Given this list of marker genes MYD88, NPC1, MIR146A, SYK, FCER1G, CD36, ADTRP (androgen dependent TFPI regulating protein), APOE, MIR4286, TGFB1, FUT1, TICAM1, CD68, LDLR, TLR4, CASR (NCBI Gene Id 846), TREM2 (NCBI Gene Id 54209), ITGB2, TXNIP, CD81, MIR135A1, MIR20A, ITGB1, ABCA1, APP, CES1, TLR6 (toll like receptor 6), MIA3, CDH13, SREBF2, MIR302A, SOCS5, MIR92A1, MIR758, LPL, SMPD3, PPARG, AKT1, CD9 (CD9 molecule), here is a description of the gene set: Human Gene Set: GOBP_RESPONSE_TO_LIPOPROTEIN_PARTICLE studied in species Homo sapiens Any process that results in a change in state or activity of a cell or an organism (in terms of movement, secretion, enzyme production, gene expression, etc.) as a result of a lipoprotein particle stimulus.